The following is a description of a gene set: Genes having at least one occurrence of the motif TWTTTAATTGGTT in the regions spanning 4 kb centered on their transcription starting sites. This matches the NKX6-1 transcription factor binding site V$NKX61_01 (v7.4 TRANSFAC). Human Gene Set: NKX61_01 species: Homo sapiens, and this is the list of marker genes: PNMA1, IMMP1L, CCDC91, PTPN22, MAP2 (microtubule associated protein 2), PRRX1, SOX18, KCNJ16, AOC2, BBS12, VCPKMT, TCF4, EYA1, TCL1A, BRCA2, RNF152, WNK1, MAN1C1, PHF21A, LLGL2, CHCHD7, RNF4, ZIC4, PPARGC1A, GJD2, GATA3, PDGFRA, DSG4, FAR2, TENM1, SLC38A6, AK8, TSHZ2 (NCBI Gene Id 7765), PPP3CB, CGA, NCOR1, LRRTM1 (NCBI Gene Id 347730), PRKAG1, UBE2C, FHL1, SKAP1, SAT1, NR4A3, SLITRK3, FOXP2, WNT7A (Wnt family member 7A), SIK2, HRK, HABP2, HOXC6, RBBP8, TMTC2, RHOBTB3, GNAT2, TRIM8, LARGE1, LHX6, JAKMIP2, NDUFA4, SLC20A1, CLK2, AMMECR1, C1QTNF7, TMEM88, ADGRB3, MARCKS, AMY2B, FAM53B, FAM81A, ACMSD, MYT1, DTNA, PTGR3, COL11A2, CREB5, KLF14, PURA, ANGPT2, SEZ6L, OLFM4, ETS2, CAVIN2, RAB5B, CUL3, SOX5, TUT1, PCMTD1, MID1, ATP2A2 (NCBI Gene Id 488), CCND2, CLOCK, TBX5, NEUROD6, DUSP6, ELP4, RIMS2, PLXNA2, DMP1, CASZ1, MIR17HG, ZFPM2, SLC6A15, STOML2, HSD17B2, DCDC1, PTPRD, PLRG1, ARX, CTNND1, FGF7, HOXA11, CADM1, KMT2C, PRDM13, VAMP3, MYO10 (NCBI Gene Id 4651), FAM83F, LMO1, RAB3C, EDA, RUNX1T1, TOB1, WNT8B, ARID5A, NECAP1, FEZF2, PCSK2, PLCB1, ARHGAP44, MYF6, ANXA10, NOL4L, KCNIP2, AARS2, TMEM62, TBXAS1, FLI1, HOXC10, HOXD8, SOAT1, HESX1, CLRN1, ZRANB1, NIPBL, MDGA1, DSG1, KCNN3, NRN1L (neuritin 1 like), FGFBP3, DDX17, ERMAP, OTP, HOXA7, NSD1, CDK11A, FUT11, AP3M2, PDZRN4, SLC26A7, FGF12, CNTLN, HOXC4, SAMD11, PHOX2B, POU3F4, BCL6, ELF4, HSD11B1, SALL3, LINC03122, NEUROD2, EN1, TLE4, HYPK, LMO3, SHKBP1, NPR3, SLC6A4, FGFR2, CXCL13 (NCBI Gene Id 115545), LMNA, GTF2A1L, NR2F1, HOXB8, RPA3, CHD6, QRFP, SSBP3, RNF19B, ZFP36L1, KLHL5, MBNL2, CABCOCO1, APOBEC2, GABRB2, BOC, CCSER2, FOXP3, LGI1, ZBTB20, GK2 (NCBI Gene Id 2712), RARB, SLITRK2 (SLIT and NTRK like family member 2), CHD2, SIAH3, SH3BGRL3, GAD2, IRX4, EDC4, PPM1E, NEUROG1, ITGA7, RBFOX1, SV2A, NTNG2, SESN3, SATB2 (NCBI Gene Id 80104), ERG, TYRO3, SOX4, PLCD4, CDH10, ESRRG, CDKL5, SLC12A6, HNRNPA0, ST8SIA2, RNF43 (NCBI Gene Id 54894), CDK11B, CEP120, ALDH1A2, USF2, KLF15, SPACA9, NHLH2